Given this list of marker genes SLC25A24, SLC17A9, SLC25A25, SLC25A41, SLC25A17, SLC25A42 (solute carrier family 25 member 42), SLC25A31, SLC25A4, SLC25A6, SLC25A23, SLC25A5, SLC35B1, here is a description of the gene set: studied in species Homo sapiens Human Gene Set: GOBP_ADP_TRANSPORT The directed movement of ADP, adenosine diphosphate, into, out of or within a cell, or between cells, by means of some agent such as a transporter or pore.